Given this list of marker genes ADM, PDE3A (phosphodiesterase 3A), PTPRJ, ARHGAP35, TJP2, HRH1, CDH5, PDE2A, TJP1, AZU1, DDAH1, PTP4A3, PLVAP, TACR2, RAMP2, ZEB2, TGFB1 (transforming growth factor beta 1), AMOT, ANGPT1 (NCBI Gene Id 284), CEACAM1, TACR1, ADORA2A, SH3GL2, PLEC, C2CD4A, CTNNBIP1, C2CD4B, GPR4, BDKRB2, TEK, AKAP12, NPR1, UCN, APOE, TRPV4, YES1, SRC, NPPB, BMP6, TJP3, VEGFB, CLDN5, FGFBP3, SLIT2, ABCC8, OCLN, BCR, VEGFA, FERMT2, MIR23A, here is a description of the gene set: Any process that modulates the extent to which blood vessels can be pervaded by fluid. studied in species Homo sapiens Human Gene Set: GOBP_REGULATION_OF_VASCULAR_PERMEABILITY